Given this list of marker genes Csnk2b, Atg12, Sqstm1, Vdac2, Vdac3, Ube2n, Mfn2, Tomm5, Fundc1, Tomm6, Tomm20, Tomm7, Pgam5, Ube2v1, Mterf3, Rps27a, Pink1, Map1lc3b, Prkn, Vdac1, Ulk1, Tomm22, Optn, Ubb, here is a description of the gene set: part of: Selective autophagy Reactome Pathway: Mitophagy electronically inferred by orthology from the curated human pathway This event has been computationally inferred from an event that has been demonstrated in another species.<p>The inference is based on the homology mapping from PANTHER. Briefly, reactions for which all involved PhysicalEntities (in input, output and catalyst) have a mapped orthologue/paralogue (for complexes at least 75% of components must have a mapping) are inferred to the other species. studied in species Mus musculus